Given this list of marker genes TLR4, IQGAP1, SRC, DDIT3, ITGB3, MIR4632, PDGFB, ERRFI1, CCNA2, HDAC1, YES1, HAS1, MARS1, PDGFRB, CBL, CREB1, FYN (NCBI Gene Id 2534), FER, CORO1B, SYAP1, MIR1298 (NCBI Gene Id 100302153), RDX (radixin), HAS2, PDGFD, HYAL1, MTSS2, PTPN1, here is a description of the gene set: Human Gene Set: GOBP_RESPONSE_TO_PLATELET_DERIVED_GROWTH_FACTOR Any process that results in a change in state or activity of a cell or an organism (in terms of movement, secretion, enzyme production, gene expression, etc.) as a result of a platelet-derived growth factor stimulus. studied in species Homo sapiens